The following is a description of a gene set: Any process that results in a change in state or activity of a cell or an organism (in terms of movement, secretion, enzyme production, gene expression, etc.) as a result of an electromagnetic radiation stimulus. Electromagnetic radiation is a propagating wave in space with electric and magnetic components. These components oscillate at right angles to each other and to the direction of propagation. Human Gene Set: GOBP_RESPONSE_TO_RADIATION studied in species Homo sapiens, and this is the list of marker genes: ATP1A2, PER1, COPS3, KDM4D (lysine demethylase 4D), RIC8A, DCT, TP53I13, PDE6B, UBE2B, TOP1, DRD1, CASP3, GTF2H2, RAD54L, TRIAP1, APP, FBXL21P, GRK4, CDKN1A, EYA3, DDHD2, XRCC5, POLD3, PAXIP1, RAD1, BRCC3 (NCBI Gene Id 79184), TLK2, ATM, PPP1CB, NSMCE3, PTPRK, ATR, PARTICL, LRRN4, LZIC, MT-ND3, BCL2L1, HSF1, CYP2R1, BRCA1, CDC25A (cell division cycle 25A), CAT, MYC, TNKS1BP1, ABCG5, BABAM1, DRD3, ATXN1, METTL3, USP28, LARGE1, RBP4, TUBA1A, COL6A3, MMP9, HYAL1, BRAF, NMU, CCL11, MECP2, ASIC2, RRH, KCNC2, GPSM2, MTA1, OPN1MW2, XPA, TOPBP1, FECH, CCND2, SLC24A2, MTCH2, BRSK1, KAT5, TANC1, PRKCD, PCLAF, PRIMPOL, OPN4, BBC3, TMEM109, DBH, MIR21, HUS1, CDK5, GJA10, TGFB1, EIF2AK4, MMP2, GNAT1, BBS10, VCAM1, HOXA1, CCL7, GRK7, PPM1D, ERCC1, CRTC1, ELANE, IL12B, SWI5, NEDD4, SPRTN, RGS9BP, GPR52, PPP1R1B, ID2, FBXO4 (F-box protein 4), OPN1MW (opsin 1, medium wave sensitive), GNGT1, RHNO1, NF1, TYR, CACNB4, SIRT6, RAD51, SIK1, CRY2, PPID, CLK2, SOD2, AEN, RFWD3, RHOB, GUCA1ANB-GUCA1A, SYNGAP1, POLB, FEN1, ABCC8, CYBA, PNKP, ECT2, PIK3R1, RDH13, ST20 (suppressor of tumorigenicity 20), FBXW7, CACNA2D4, NPHP1, KDM1A, LIG4, THBD, RGS9, CERS1, PRPH2, CCND1, BAX, MAPK10, CBL, PBK, POLA1, BARD1, N4BP1, SEMA5B, AKT1, SMC1A, CUL4A, BLM, SDF4, XRCC6, SLC1A2, TRIM32, COMT, DDB1, PRKAA1, RAD9B, DHX36, BABAM2, SPIDR, TP53BP1, MAP2K7, GATA3, SLC24A1, NPY, CREB1, RP1, STK11, CRYAA, FBXL3, CNGB1, ABRAXAS1, MYO15A, KRT14, APOBEC1, RGR, GRM6, ERCC6, KCNC1, MC1R, OPN1LW, PCNA (proliferating cell nuclear antigen), CUL4B, PARP1, TREX1, MAPK11, SLC1A3, NMT1, RBM4, AURKB (NCBI Gene Id 9212), YY1, GUCY2F, OPN1MW3, HRH1, ZMPSTE24, ERCC2, PER3, TRPC3, GPR88, EGFR, RPAIN, SLC4A10, MEIS2, TANK (NCBI Gene Id 10010), ELK1 (ETS transcription factor ELK1), NR2E3, TTC36, MAP3K4, EIF2S1, PER2, RRM1, ERCC4, ERCC8, SFRP2, REEP6, OPN1SW, H2AX, RHBDD1, DRD2, TP53INP1, NABP1, ERCC5, SMPD1, MFAP4, PRKDC, NOG, LRIT3, YAP1, HMGCR, CRIP1, CCAR2, MMP3, PITPNM1, CASP9, GTF2H5, CCDC66, EYS, ERCC3 (NCBI Gene Id 2071), POLH, BHLHE40, TTR, HYAL2, CAMKMT, CREBBP, KARS1, ZRANB3, LCN10, IFT20, NMT2, TAFA2, MAPK14, CASP7, SNAI2, RO60, GRB2, SLC24A4 (solute carrier family 24 member 4), ELOVL4, COPS9, PML, PLK3 (NCBI Gene Id 1263), MAP4K3, MEN1, ADAM2, GNB5, AQP1 (NCBI Gene Id 358), CHRNB2, GUCA1A (NCBI Gene Id 387091), KRAS, HYAL3 (NCBI Gene Id 8372), INO80, UBE2A, UIMC1, OPN5, ATP8A2, SCARA3, INTS3, HRAS, RAD54B, AKT2, USP2, LCN2, ITGB1, BMF, PLN, NDRG4, PDE6C, GNA11, REV1, LRIT1, PPP1CC, PTPRC, SERPINB13, CIRBP (cold inducible RNA binding protein), NUCKS1, RHO, MAP3K20, SLC7A11, IKBIP, NR2F6, RUVBL2, FANCD2, MMP1, TXN, CTNS, PRAP1, FOS, NFATC4, TMEM161A, ITGB6, TULP1, MAPK13, TAF1, ABCA4, IFI16, ALAD (NCBI Gene Id 210), USP1, KMT2A, IL12A, POLD1, RNF8, COL6A1, TP53 (tumor protein p53), KIT, PNPLA2, CACNA1F, SCN11A, CHEK2, XRCC4, GUCY2D, XRRA1, TIGAR, SAG, IVL, COL6A2, INIP, MAPK8, H2AC25, TNF, NHEJ1, GPX1, OPN3, BEST1, B3GAT1, ROM1, DCUN1D3 (defective in cullin neddylation 1 domain containing 3, NCBI Gene Id 123879), EYA1, NPS (NCBI Gene Id 594857), PIANP, DCLRE1C, HMGN1, SDE2, UBE4B, TIMP1, INTS7, AGRP, TICRR, GADD45A, BCL2, ABCA7, RPE65, MRNIP, TSPYL5, TIPIN (TIMELESS interacting protein), WRN, CEP250, CXCL10, BAK1, EEF1D, PPP1CA, EGR1 (early growth response 1), XRCC2, CDKN2D (cyclin dependent kinase inhibitor 2D), DUSP1, CABP4, NIPBL, ATF4, MME, DTL, RAD51AP1, DEAF1, GRIN1, GNAT3, UVSSA, BRAT1, FRMPD1, EI24, GNAT2, NABP2, TRPM1, DNMT3A, PLEKHB1, CLOCK, NETO1, UNC119, RAD9A (RAD9 checkpoint clamp component A), FKBPL, CPT1B, USF1, COL3A1, JUND, RPL26, SFRP1 (secreted frizzled related protein 1), XPC, BRCA2, CRYAB (NCBI Gene Id 1410), GRK1, BCL3, RNF168, COP1, NET1, PDE1B, MSH6, FOXB1, CRY1, EP300, RCVRN, CDS1, AIPL1, MSH2, MDM2, SIRT1, GNGT2, RBX1, HIF1A, NLRP1, GRIN2A, PIERCE1, EXT1, AANAT, ACTR5, PDE8B (NCBI Gene Id 8622), RBM4B, DDB2, OGG1, POLK, GNAQ, PIAS1, GUCA1B, NPM1, RGS14, NOC2L, FIGNL1, B4GALT2, DYNLRB1, ATOH7, PDC, NPHP4, PCP2, CRB1, FANCG, RELA, ZBTB1, RAG1